The following is a description of a gene set: species: Mus musculus Mouse Gene Set: GOCC_MICROTUBULE_ORGANIZING_CENTER_ATTACHMENT_SITE A region of the nuclear envelope to which a microtubule organizing center (MTOC) attaches; protein complexes embedded in the nuclear envelope mediate direct or indirect linkages between the microtubule cytoskeleton and the nuclear envelope., and this is the list of marker genes: Kash5, Syne1, Spag4, Syne2, Sun3, Sun2, Sun5, Clmn, Syne3, Sun1, Syne4